The following is a description of a gene set: species: Mus musculus Reactome Pathway: Dual incision in TC-NER part of: Transcription-Coupled Nucleotide Excision Repair (TC-NER) This event has been computationally inferred from an event that has been demonstrated in another species.<p>The inference is based on the homology mapping from PANTHER. Briefly, reactions for which all involved PhysicalEntities (in input, output and catalyst) have a mapped orthologue/paralogue (for complexes at least 75% of components must have a mapping) are inferred to the other species. electronically inferred by orthology from the curated human pathway, and this is the list of marker genes: Prpf19, Polr2c, Polr2l, Gtf2h2, Polr2a, Uvssa, Rfc3 (NCBI Gene Id 69263), Polr2e, Ercc6, Pole2, Polr2f, Polk, Cul4b, Ccnh, Ercc1, Polr2b (NCBI Gene Id 231329), Gtf2h4, Pold4, Tcea1, Xab2, Rfc1, Pold2, Ercc4, Pcna, Ercc3, Ddb1, Polr2i, Rps27a, Ercc2, Ubb, Cul4a, Rpa1, Polr2k (NCBI Gene Id 17749), Pole, Xpa, Pold1, Zfp830